The following is a description of a gene set: The directed movement of substances from the Golgi to the plasma membrane in transport vesicles that move from the trans-Golgi network to the plasma membrane, where they fuse and release their contents by exocytosis. Human Gene Set: GOBP_GOLGI_TO_PLASMA_MEMBRANE_TRANSPORT studied in species Homo sapiens, and this is the list of marker genes: CSK, STXBP5L, RAB26, SEC16A, STXBP5, GOLPH3, LYPLAL1, AMN, GGA2, RABEP1, PHAF1, ARL3, VPS35L, RAB11FIP3, EXOC4, PKDCC, NSF, OPTN (optineurin), COMMD1, SYS1, EXOC6, PREPL, KRT18, MACF1, VAMP2 (vesicle associated membrane protein 2), EXOC2, RAB11A, LLGL1, LLGL2, SPTBN1, RAB3IP, ANK3 (NCBI Gene Id 288), GGA1, ATP2C1, GCC2, GGA3, GOLGA7, CCDC93, CCDC22, CNST, ACSL3, VAMP4, RAB34, VAMP5, RAB13, ARFGEF2, BBS2, RAB31, ARFRP1, LYPLA1, RSC1A1, BLZF1, EXOC1, EXOC5, OSBPL5, ANXA13, RAB10, GOLGA4, GOPC, RACK1, KIF13A, STEAP2, VAMP3, GOLPH3L, EXOC6B, CLN3, BBS1, EXOC8 (NCBI Gene Id 149371)